The following is a description of a gene set: Mouse Gene Set: GOMF_PHOSPHORIC_DIESTER_HYDROLASE_ACTIVITY species: Mus musculus Catalysis of the hydrolysis of a phosphodiester to give a phosphomonoester and a free hydroxyl group., and this is the list of marker genes: Pde4d, Pde3a, Pde1a, Plcl1 (NCBI Gene Id 227120), Mpped2, Plcb4, Plcxd1, Hras, Pde4c, Eed, Enpp6, Plcb2, Hmox1, Pde6g, Pde7b, Mppe1, Plcd3, Pld2, Smpdl3a (NCBI Gene Id 70336), Pde6d, Gdpd5, Ccr1, Pld6, Pld3, Arf1 (NCBI Gene Id 11840), Plcxd3, Enpp7, Plcg2, Enpp2, Plcl2, Gpld1, Napepld, Pde8b, Pde5a, Plcg1, Pde4b, Cnp, Plch2, Stx4a, Gdpd3, Pde9a, Pde6h, Gdpd1, Pld4, Smpd1, Pde4a (phosphodiesterase 4A, cAMP specific), Nsmaf, Smpdl3b, Pde10a, Enpp1, Fan1, Tdp2, Gna11, Arf4, Gpcpd1, Plch1, Smpd5 (sphingomyelin phosphodiesterase 5), Tulp2, Pde3b, Plcb3, Ccr1l1, Apex2, Pde6b (NCBI Gene Id 18587), Pde11a, Gnas (GNAS complex locus), Plcd1, Ccl5, Adprm, Pld1, Arl1, Tdp1, Pde1b, Plcd4, Gde1, Gnb1, Plcb1, Pde6c (NCBI Gene Id 18581), Ficd, Plce1, Smpd2, Apex1, Pde1c, Smpd4, Enpp3, Pde2a, Plcxd2, Pde8a, Smpd3, Pde6a, Gdpd2, Gnaq, Pde7a, Pdgfra, Gdpd4, Plcz1